Given this list of marker genes Myb, Tmem60, Ly6d, Ctsh, Parp3, H2-Q7, Mus81 (MUS81 structure-specific endonuclease subunit), Cd52, Swap70, Icam1 (NCBI Gene Id 235038), Sf1, Idi1, Sco2, here is a description of the gene set: Cytokines mediate cell-cell communication in the immune system and represent important therapeutic targets. A myriad of studies have highlighted their central role in immune function, yet we lack a global view of the cellular responses of each immune cell type to each cytokine. To address this gap, the authors created the Immune Dictionary, a compendium of single-cell transcriptomic profiles of more than 17 immune cell types in response to each of 86 cytokines (>1,400 cytokine-cell type combinations) in mouse lymph nodes in vivo. A cytokine-centric view of the dictionary revealed that most cytokines induce highly cell-type-specific responses. For example, the inflammatory cytokine interleukin-1β induces distinct gene programmes in almost every cell type. A cell-type-centric view of the dictionary identified more than 66 cytokine-driven cellular polarization states across immune cell types, including previously uncharacterized states such as an interleukin-18-induced polyfunctional natural killer cell state. species: Mus musculus Mouse Gene Set: CUI_PDC_IL17E_RESPONSE_UP from publication Cui A, Huang T, Li S, Ma A, Pérez JL, Sander C, Keskin DB, Wu CJ, Fraenkel E, Hacohen N (PMID 38057668) Genes positively differentially expressed in cell type: pDC (plasmacytoid dendritic cell) upon treatment with cytokine: IL-17E in mouse lymph nodes in vivo.